The following is a description of a gene set: from publication Konuma T, Nakamura S, Miyagi S, Negishi M, Chiba T, Oguro H, Yuan J, Mochizuki-Kashio M, Ichikawa H, Miyoshi H, Vidal M, Iwama A (PMID 21540074) species: Homo sapiens Genes up-regulated in comparison of lineage negative versus CD4 T cells. Human Gene Set: GSE27786_LIN_NEG_VS_CD4_TCELL_UP Each fraction of mouse hematopoietic cells was purified by cell sorting from bone marrow of 8-week-old C57BL/6 mice, and its gene expression was analyzed., and this is the list of marker genes: TMEM176B, GPSM2, POLR2H, TEFM, ARAP3 (ArfGAP with RhoGAP domain, ankyrin repeat and PH domain 3), FZD3, ABCB6, NSUN2, MFSD13A, IRX1 (iroquois homeobox 1), YBX1 (NCBI Gene Id 7806), SFXN2 (sideroflexin 2), IRAK1BP1, ACACA, ZDHHC13, DPAGT1, RHOBTB1, ELAC2 (NCBI Gene Id 60528), CEP78, FARSA (NCBI Gene Id 2193), IPO5, DEPDC1B, VWC2, OLA1, NDUFB2 (NADH:ubiquinone oxidoreductase subunit B2), HES3, TM9SF4, EIF2S1, SELENOI (selenoprotein I), FHL1, NCCRP1, SUV39H2, DIABLO, METTL15, SLC48A1, PTPRK, GCSH, REPIN1, NCBP1 (nuclear cap binding protein subunit 1), ASNSD1, STEAP3, PNO1, TTLL12, ACSL3, TFG, PCGF6, MYCT1, AQP9, PRADC1, DCN, ELN, TUBA1B, FBXL15, STT3B, HAPLN4, SLC25A22, GP5, CDC25A, MRPL42, IGFBP3, VPS50, POLD2, ATL1, TPP1, SAMD1, CKAP4, WDR74, SRRM1, REEP6, SPATA24, FIRRM, FNIP2, DYNC2I2, MRPL48, CCNB2 (cyclin B2), PSMG2, DBI, MAPK8, ANKRD49, SQOR (NCBI Gene Id 58472), PON1, IPO4, AGO4 (argonaute RISC component 4), ISCA2, SPI1, SLC5A2, DBF4, DMWD, ZRANB3, TICRR, MFSD12, MATCAP2 (microtubule associated tyrosine carboxypeptidase 2), MTM1, ANKLE1, CLPX, PTOV1, CASQ1, TOPBP1, FAM185A, TMT1A, KRT18, EIF4E, SLC25A3, LMNA, TEX29, AP2A1, SOX8, CCNF, EMC10, P4HB, PUM3 (pumilio RNA binding family member 3), TLR2, RUSF1 (NCBI Gene Id 64755), IDH2, C9orf43, PFKFB4, SERPINE2, RBL1, SGCE, SSR3, DMKN (NCBI Gene Id 93099), NTPCR, BET1, SYK, CLNS1A, PPP1R2P1, TTK, TIMM8B, AARSD1, SPAG4, CUL2, GLT8D2 (NCBI Gene Id 83468), MRS2, NOP16, SLC6A13, ELP5, CLEC4G, SYT4, CD81, PSPC1, AFDN, ZFYVE21, ABCB10, ZNRD2, PALB2, NR2F2, HOOK2, SPRED1, THSD7A, DHFR, TMEM222, PPIE, RABGGTB, GALNS, TUFT1, SRSF9, HDAC6, SORT1, ALOX5AP, NCF1, FADS1, TDP1, NDUFAF4, HUNK, KIFC3, NHP2, LRP12, UBE2J2, TMEM69, BCL2L12, CAD, PDYN, HRAS, ECI2, C9, HEBP1, TMEM106C, TIMM10, AMMECR1, NOP56, CDK2, AUNIP, SCAP, CAMK1, GRWD1, BSN, AGPAT5, NRIP3, OAT, SMPD4, KLHL12, NDUFS1, HMGXB4 (NCBI Gene Id 96789), NFIC, LRRC59, METAP2, SEC24D, HSPBP1, CLYBL, MMGT1